Given this list of marker genes Irs2, Ifng, Ptpn22, Spry1, Gnaq, Dusp1, Pdcd4, Socs4, Prdx3, Prkrip1, Hhex, Ptpn2, Sirt1, Sfrp5, Lilrb4a, Mapt, Xrcc1, Macroh2a1, Setd7, Trib3, Nup62, Pten, Ptprb, Tsc2, Ptprh, Spred1, Gstp2, Smyd3, Garem1, Gstp-ps, Banf1, Aida, Irak3, Dusp7, Ptprc, Uchl1, Rpl5, Midn, Cep43, Taf7, Slc8a3, Dusp10 (NCBI Gene Id 98270), Mad2l1, Rps7, Pkib, Usp44, Rgs14, Blvra (biliverdin reductase A), Ptpro, Mvp, Myocd, Hexim2, Dnaja1, Gadd45g, Hnrnpu, Agt, Dnajc3, Smpd1, Dab2ip, Cdkn2c, Prkar1a (protein kinase, cAMP dependent regulatory, type I, alpha), Trim27, Nppa, Dbndd2, Gskip, Limk1, Wars1, Srcin1 (NCBI Gene Id 56013), Pnkp, Cav1, Cdk5rap1, Dusp22, Adarb1, Hipk3, Chmp6, Ajuba, Cln8, Lats1, Fbxo7, Lats2, Phpt1, Cep85, Ormdl3, Gadd45b, Bag2 (BCL2-associated athanogene 2), Inca1, Abl1, Epha1, Spry2, Shb, Slc8a1, Prkag2, Fem1a, Psen1, Hmgcr, Mllt1, Bmp2, Gstp3 (glutathione S-transferase pi 3), Deptor, Adar, Rasip1, Cav3, Eif4a2 (eukaryotic translation initiation factor 4A2), Socs5, Pkig, Npm1, Itgb1bp1, Gba1, Tigar, Cdkn1a, Lrp6, Akt1 (NCBI Gene Id 268604), Thy1, Stk38, Ppm1f, Prkca, Ptprt (NCBI Gene Id 19281), Nf1, Rgs2 (regulator of G-protein signaling 2), Cdkn1b, Ggnbp2, Casp3, Ptpn6, Il1b, Prkn, Prkch, Fbxo5, Errfi1, Trib1, Dusp19, Prkcd, Rpl23, Apoe (apolipoprotein E), Dusp3, Pkn1, Hyal2, Smad7, Pkia, Ppia, Cdkn1c, Mstn, Park7, Wnk4, Ceacam1, Bag5, Mad2l2, Plk1 (polo like kinase 1), Rtraf, Gsk3a, Zfp36, Adipoq, Coro1c, Chp1 (NCBI Gene Id 80510), Wee2, Mapk8ip1, Qars1, Ubash3b, Lilrb4b, Zgpat, Gstp1, Zfyve28, Rb1, Wwtr1, Ptk6, Spry4, Gprc5a, Nolc1, Apc, Kat2b (K(lysine) acetyltransferase 2B), Hspb1, Rpl11, Fabp4, Ptpn1, Tfap4, Cdk5rap3, Ppm1e, Sh3bp5, Sfrp1, Psen2, Sfrp2, Cdkn2a, Paqr3 (NCBI Gene Id 70746), Cd300a, Gadd45a, Chordc1, Akt1s1, Ptprj, Vps25, Pparg, Nf2, Plec, Pycard, Tsg101, Dnaja3, Nprl2, Men1, Gckr, Heg1, Cblc, Lyn, Inpp5k, Cox11, Nr2f2, Dtnbp1, Dtx3l, Acp4, Tnfaip3, Tinf2, here is a description of the gene set: Mouse Gene Set: GOBP_NEGATIVE_REGULATION_OF_TRANSFERASE_ACTIVITY species: Mus musculus Any process that stops or reduces the rate of transferase activity, the catalysis of the transfer of a group, e.g. a methyl group, glycosyl group, acyl group, phosphorus-containing, or other groups, from a donor compound to an acceptor.